The following is a description of a gene set: Mouse Gene Set: GOCC_COCHLEAR_HAIR_CELL_RIBBON_SYNAPSE A ribbon synpase of an auditory hair cell of the cochlear. These ribbon synapses contain spherical synaptic ribbons and lack and arciform density. species: Mus musculus, and this is the list of marker genes: Myo6, Cacna1d, Bsn, Camk2d (NCBI Gene Id 77170), Otof, Cdh23